Given this list of marker genes DNAJC21, SPI1, CLPB, IRAK4, SBDS, FIBP, EFL1, here is a description of the gene set: Human Gene Set: HP_TRANSIENTLY_DECREASED_TOTAL_NEUTROPHIL_COUNT studied in species Homo sapiens Transiently decreased total neutrophil count Abnormal decrease of the absolute number of neutrophils in the blood, per microlitre, compared to a reference range for a given sex and age-group, which persists for less than 3 months and then spontaneously recovers, but does not recur cyclically.